Given this list of marker genes NRAS, KRAS, HRAS, here is a description of the gene set: Reactome Pathway: Signaling by RAS GAP mutants part of: RAS GTPase cycle mutants studied in species Homo sapiens This pathway describes RAS mutants whose intrinsic GTPase activity can't be stimulated by GTPase activating proteins (GAPs). These RAS mutants therefore support increased RAS pathway activity.